Given this list of marker genes GALR1, CRY1, CRHR1, POMC (NCBI Gene Id 5443), PTPN11, KCNQ1, GAL, DAB2, SELENOM, KCNK9, CRH, BMP6, CRY2, GHRL, TAC1, AGTR1, AGT, WNK4, C1QTNF1, TSPO, REN, ECRG4, here is a description of the gene set: The regulated release of any corticosteroid hormone into the circulatory system. studied in species Homo sapiens Human Gene Set: GOBP_CORTICOSTEROID_HORMONE_SECRETION